Given this list of marker genes S100A8, COL19A1, COL26A1, PLAT, COL17A1, S100A16, MMP19, MMP1, FBLN5, OGN, FLG2, NGLY1, here is a description of the gene set: Human Gene Set: NABA_MATRISOME_POORLY_METASTATIC_BREAST_CANCER_TUMOR_CELL_DERIVED Tumor-cell-derived matrisome proteins exclusively detected in poorly metastatic breast cancer human-to-mouse xenografts (MDA-MB-231) in comparison to highly metastatic breast cancer human-to-mouse xenografts (MDA-MB-231_LM2) studied in species Homo sapiens from publication Naba A, Clauser KR, Lamar JM, Carr SA, Hynes RO (PMID 24618895) To define the ECM composition of tissues and tumors, we have empolyed a proteomics-based method to enrich and identify ECM proteins and coupled it with a bioinformatic annotation of the matrisome defined as the ensemble of ECM and ECM-associated proteins. To identify ECM proteins important for breast cancer progression and metastasis formation, we used a xenograft model where human breast cancer cells of differing metastatic potenital were orthotopically injected into the mouse mammary fat pad. The poorly metastatic MDA-MB-231 cell line was established from cells isolated from a sample from a triple-negative breast cancer patient. The highly metastatic MDA-MB-231-LM2 line (denoted LM2), was previously selected and characterized for increased metastatic potential to the lungs. 6.5 weeks post-injection, the primary tumors were harvested, ECM proteins were enriched from tumors, and the composition of the ECM-enriched fractions obtained was characterized by mass spectrometry. We define the matrisome of a tumor as the ensemble of proteins detected in two independent biological replicates and by at least two peptides in one of the two replicates. Using this proteomics approach we show that both the tumor cells and the stromal cells contribute in characteristic ways to the production of the tumor ECM. Moreover, we show that both tumor- and stroma-derived proteins differ between tumors of different metastatic potential. Comparison of the matrisomes of MDA-MB-231 tumors and LM2 tumors identifies ECM proteins characteristic of poorly and highly metastatic tumors. This gene set lists the matrisome proteins secreted by the tumor cells in MDA-MB-231 tumors and not from LM2 tumors.